The following is a description of a gene set: Cell-cell signaling between presynapse and postsynapse, via the vesicular release and reception of brain derived neurotrophic factor (BDNF), that modulates the synaptic transmission properties of the synapse. species: Homo sapiens Human Gene Set: GOBP_TRANS_SYNAPTIC_SIGNALING_BY_BDNF_MODULATING_SYNAPTIC_TRANSMISSION, and this is the list of marker genes: SYT4, SLITRK5, PLG, PLAT, NTRK2